The following is a description of a gene set: species: Homo sapiens Abnormality of primary teeth Any abnormality of the primary tooth. Human Gene Set: HP_ABNORMALITY_OF_PRIMARY_TEETH, and this is the list of marker genes: ERCC1, FGFR1, C1S (complement C1s), MSX1, PRKD1, VAC14, FGFR2, EDNRA, KCNJ2, EHMT1, FIG4, ZMPSTE24, EDARADD, TCIRG1, SNRPN, DEAF1, FAM111A, CSTB, COL3A1, ZFX, FERMT1 (NCBI Gene Id 55612), RAB23, FLNA, PCGF2, TGFA, IRF6, IL6ST, TMCO1, ERCC6, GJA1, PURA, RAI1, SRCAP, EDAR, C1R, KCNJ5 (NCBI Gene Id 3762), ERCC8, SNX10, TNFSF11 (TNF superfamily member 11), CTSK, WNT5A, PAX9, AXIN2, TRAF6, HNRNPK, DVL1, CLCN7, LEMD2, CTSC, PTH1R, ZBTB7A, IQSEC2, CBFB, WDR26, ALPL, WNT10A, SFRP4, STAT3, SUMO1, CAMK2B, TFAP2B, WNT10B, SMARCAL1, BCOR, CA2, ERCC4, KDM6A, LRP6, LMNA, NDUFB11, ANKH, KMT2D, B4GALT7, VDR, PUS7, RHOA, UBR1, KIF7, KDF1, RNF113A, RUNX2, FLII, EDA